Given this list of marker genes Nmnat3, Slc22a13, Nnmt (NCBI Gene Id 18113), Naprt, Bst1, Nampt, Nmnat2, Slc25a51, Slc5a8, Naxd, Nudt12 (nudix hydrolase 12, NCBI Gene Id 67993), Rnls, Cd38, Nmrk2, Qprt, Nmnat1, Nt5e, Nadsyn1, Naxe, Nadk2, Nmrk1, Nadk, here is a description of the gene set: Nicotinate metabolism species: Mus musculus Mouse Gene Set: REACTOME_NICOTINATE_METABOLISM